The following is a description of a gene set: species: Homo sapiens The growth of a chondrocyte, where growth contributes to the progression of the chondrocyte over time. Human Gene Set: GOBP_CHONDROCYTE_HYPERTROPHY, and this is the list of marker genes: EXT1, TGFBR2, SOX9, SMAD7, MEX3C, RARG